The following is a description of a gene set: NF-kappaB signaling is implicated as an important regulator of skeletal muscle homeostasis, but the mechanisms by which this transcription factor contributes to muscle maturation and turnover remain unclear. To gain insight into these mechanisms, gene expression profiling was examined in C2C12 myoblasts devoid of NF-kappaB activity. Interestingly, even in proliferating myoblasts, the absence of NF-kappaB caused the pronounced induction of several myofibrillar genes, suggesting that NF-kappaB functions as a negative regulator of late-stage muscle differentiation. Although several myofibrillar promoters contain predicted NF-kappaB binding sites, functional analysis using the troponin-I2 gene as a model revealed that NF-kappaB-mediated repression does not occur through direct DNA binding. In the search for an indirect mediator, the transcriptional repressor YinYang1 (YY1) was identified. While inducers of NF-kappaB stimulated YY1 expression in multiple cell types, genetic ablation of the RelA/p65 subunit of NF-kappaB in both cultured cells and adult skeletal muscle correlated with reduced YY1 transcripts and protein. NF-kappaB regulation of YY1 occurred at the transcriptional level, mediated by direct binding of the p50/p65 heterodimer complex to the YY1 promoter. Furthermore, YY1 was found associated with multiple myofibrillar promoters in C2C12 myoblasts containing NF-kappaB activity. Based on these results, we propose that NF-kappaB regulation of YY1 and transcriptional silencing of myofibrillar genes represent a new mechanism by which NF-kappaB functions in myoblasts to modulate skeletal muscle differentiation. studied in species Mus musculus from publication Wang H, Hertlein E, Bakkar N, Sun H, Acharyya S, Wang J, Carathers M, Davuluri R, Guttridge DC (PMID 17438126) Representative genes up-regulated in C2C12 cells (myoblast) lacking NFkB activity due to expression of a super repressor form of NFKBIA. Mouse Gene Set: WANG_NFKB_TARGETS, and this is the list of marker genes: Hoxa1, Miox, Csrp3, Actc1, Aplnr, Traf5, Tnnt1, Myh7, Atp2a1, Tnni1, Rarg, Myh1, Foxa2, Cish (cytokine inducible SH2-containing protein), Mef2b, Chrng, Myl4, Cma1, Casp7, Itgb5, Tnnc1, Sh3bp1, Cav3, Notch1